Given this list of marker genes Cox16, Prkaa2, Htatsf1, Tshz1, Tmem127, Adcy1, Ablim3, Apc, Nr6a1, Zfp974, Atp1a1, Zfp629, Zfp148, Zfyve16, Ppp6c, Srsf3, Mettl9, Kctd1, Chodl, Septin7, U2af2, Or7a38, Cnpy1, St18, Ubxn7, Acss1, Mbd3, Apbb2, Anxa9, Rsad1, Stat4, Esp31, Tnrc6b, Sertad2, S2bpcox16, Abca8b (NCBI Gene Id 27404), Wdr37, Gbp8, Rasgef1b, Fam219a, Ubxn10, Zfp606, here is a description of the gene set: Genes predicted to be targets of miRBase v22 microRNA mmu_miR_155_3p in miRDB v6.0 with MirTarget v4 prediction scores > 80 (high confidence targets). studied in species Mus musculus Mouse Gene Set: MIR_155_3P from publication Chen Y, Wang X (PMID 31504780)